The following is a description of a gene set: from publication Yevshin I, Sharipov R, Kolmykov S, Kondrakhin Y, Kolpakov F (PMID 30445619) Genes containing one or more binding sites for (ZA_UNIPROT_Q9UM89_UNREVIEWED_GENES) in their promoter regions (TSS -1000,+100 bp) as identified by GTRD version 20.06 ChIP-seq harmonization. Human Gene Set: ZA_UNIPROT_Q9UM89_UNREVIEWED_GENES_TARGET_GENES studied in species Homo sapiens, and this is the list of marker genes: PTP4A2, RPS19 (ribosomal protein S19), RAI14, SAMD4A, PTMA, LUC7L3, ANKRD29, BASP1-AS1, ARHGAP28-AS1, CTBP1, PICART1, ASB18, NT5C2, GKAP1, LRP6, H2AC20, CCN1, DCLK2, LCOR, DGCR8, NCOA6, IRS2, HES4, PGLYRP1, TSPAN10 (NCBI Gene Id 83882), UAP1, DGUOK, BLOC1S3, EIF3A (eukaryotic translation initiation factor 3 subunit A), RPS15A, MARCKSL1P1, ZNF804B, KLF6, MIDN (NCBI Gene Id 94034), EEF1A1, BOLA1, FBXL6, NPLOC4, CUX1, BBS10, GATAD2A, HSD11B1L, NPDC1, NCOA5, FARP1, H2AX, ZFAND5, NFKBIZ, EGR1, ETV3, SLC52A2, CEP68, ADCY3, TRIM52, H4C1, JUND, CTBP1-DT, HNRNPU, MNT, LINC02939, RNF19B, MTHFD1L, ITGB1, FYN (NCBI Gene Id 2534), UAP1-DT, CLK3, ITGA3, H2BC21, PKDCC, SRSF6, DHODH, TBC1D19, ARHGAP28